Given this list of marker genes CDKN1A, RASIP1, CDKN2A, GALR1, RRP1B, RASA4, APBA3 (amyloid beta precursor protein binding family A member 3), ADIPOQ, SPOCK3 (SPARC (osteonectin), cwcv and kazal like domains proteoglycan 3), MIR138-1, MAD2L1, TAF7, GSK3A, TSG101, GSKIP, ADARB1, GNAI3, VPS25, ABCE1, PAK2, ADGRV1, PPM1E, DUSP1, GAPDH, NES, PAQR3, WARS1, USP44, CRB2, GNAT1, GSK3B, DRD5, CDK5RAP1, EPM2A, NPPA, SFN, GZMA, GABBR2, UBXN1, MACROH2A1, PLIN5, PPP1R12A, RTRAF (NCBI Gene Id 51637), LRRK2, GPRC5A, PLXNB3, EDNRB, CEP85, SERPINA5, CDKN1B (cyclin dependent kinase inhibitor 1B), ZFYVE28, CCR2, ARL2, ARFGEF1, THY1, KLRK1, CDKN1C, DFFA (NCBI Gene Id 1676), LTB4R2, PTPRJ, PTPN1, AKAP5, PRKN, MIDN, HNRNPU, TIMP2, SERPINB9, SNX6, SOCS4, ERRFI1, TIMP1, CHMP6, GCKR, RECK, LATS1, RDX, MAPK8IP1, SERPINB1, SERPINB3, PTK6, EIF4A2, CEACAM1, CAMK2A, ITGB1BP1, CEP43, CDK5RAP3, URI1, AKT1S1, PTPN22, CORO1C, INCA1, ACP4, PYCARD, CAND1, XRCC1, SRCIN1, RB1, AGT, NPRL2, TFAP4, ABL1, SERPINB8, FBXO5, CHP1, KLRC4-KLRK1, GPSM1, ATP5IF1, NPM1, LATS2, GLA, RPS7, PARP9, SERPINB4, GRM2, OXA1L, DEFB114, PDCD4, DBNDD2, USP17L2, GRM3, RPL5, PRDX5, SERPINB13, TMBIM1, FETUB, MVP (major vault protein), ADAR, PPIA, PRKCH, NEIL1, TRIM27, PRDX3, SOCS5, RGS14, YWHAG, RCC2, HIPK3, MEN1, DAB2IP, MAD2L2, APC, ECM1, CR1, STK38, TP53, NOSIP, RD3, FICD, ZGPAT, CD300A, CCAR2, RPL11, AIDA, LYN, GNAI2 (NCBI Gene Id 2771), PKIA, BANF1, DEPTOR, DNAJA1, NT5DC2, RPL23, TMED2, LRCH1, ZFP36, EPPIN, HEG1, GADD45A, DTX3L, MYCNOS, APOE, DUSP7, PTPRC, MT3, SPOCK2, NOTCH1, TARBP2, SH3BP4, here is a description of the gene set: studied in species Homo sapiens Human Gene Set: GOBP_NEGATIVE_REGULATION_OF_CATALYTIC_ACTIVITY Any process that stops or reduces the activity of an enzyme.